The following is a description of a gene set: Human Gene Set: HP_ALVEOLAR_RIDGE_OVERGROWTH Increased width of the alveolar ridges. studied in species Homo sapiens Alveolar ridge overgrowth, and this is the list of marker genes: WDR4, SC5D, ANKH, DPH5, CD96, OFD1, RBM10, PIGA, DHCR24, NTRK1, SNRPN, FTO, TBX15 (NCBI Gene Id 6913), SH3BP2, BRF1 (BRF1 RNA polymerase III transcription initiation factor subunit)